The following is a description of a gene set: Mouse Gene Set: COATES_MACROPHAGE_M1_VS_M2_UP from publication Coates PJ, Rundle JK, Lorimore SA, Wright EG (PMID 18199539) In addition to the directly mutagenic effects of energy deposition in DNA, ionizing radiation is associated with a variety of untargeted and delayed effects that result in ongoing bone marrow damage. Delayed effects are genotype dependent with CBA/Ca mice, but not C57BL/6 mice, susceptible to the induction of damage and also radiation-induced acute myeloid leukemia. Because macrophages are a potential source of ongoing damaging signals, we have determined their gene expression profiles and we show that bone marrow-derived macrophages show widely different intrinsic expression patterns. The profiles classify macrophages derived from CBA/Ca mice as M1-like (pro-inflammatory) and those from C57BL/6 mice as M2-like (anti-inflammatory); measurements of NOS2 and arginase activity in normal bone marrow macrophages confirm these findings. After irradiation in vivo, but not in vitro, C57BL/6 macrophages show a reduction in NOS2 and an increase in arginase activities, indicating a further M2 response, whereas CBA/Ca macrophages retain an M1 phenotype. Activation of specific signal transducer and activator of transcription signaling pathways in irradiated hemopoietic tissues supports these observations. The data indicate that macrophage activation is not a direct effect of radiation but a tissue response, secondary to the initial radiation exposure, and have important implications for understanding genotype-dependent responses and the mechanisms of the hemotoxic and leukemogenic consequences of radiation exposure. Up-regulated genes distinguishing between M1 (pro-inflammatory) and M2 (anti-inflammatory) macrophage subtypes. species: Mus musculus, and this is the list of marker genes: Alad, Slc7a7, Dst, Ogfrl1, Filip1l, Lama3, Rpl14, Lyplal1, Ptger3, Rapsn, Clba1, Axl, Ppp2r5c, Srd5a3, Bloc1s6, Tifab, Glo1, Hmgn3, Xlr4b, Pik3ap1, Zfp595, Zfp949, Emc1, Pianp, Tubb2b, Cadm1, P2ry13, Arfgef3, Marco, Arsb, Cd59a, Cxcl14, Atp6v0e2 (ATPase, H+ transporting, lysosomal V0 subunit E2), Cbx6, Lcorl, Gm33887, Msr1, Gm57857, Cnrip1, Slc35a1, Fam124a, Cxcr4, Galnt11, Haus2, Ocel1, Rasal2, Gda, H2-T24, Comt, Capn5, Malat1, Ada, Nat8l, Tm7sf3, Klra3, Rcbtb2, Plbd1 (NCBI Gene Id 66857), Fgd2, Tgfbi (transforming growth factor, beta induced), Plxdc2, Crim1, Rab10, Zfp979, Acss1, Gja1, Nrcam, Gatm, Abhd1, Ttc3, Marcksl1, Cfh, Hmga2-ps1, Eno2, Hddc3, Tor3a, Kcnj10, Dynlt1b, Plaat3, Txnip, Slco2b1, Cap1, Gnb4, Aif1, Rfx3, Abca9, Bckdhb, Maf, Rcn1, H2-Aa (NCBI Gene Id 406213), Gm10503, Fam135a, Sfi1, Acyp2, Colec12